The following is a description of a gene set: Increased concentration of 11-deoxycortisol in the circulation. 11-deoxycorticosterone, which is also known as simply deoxycorticosterone and 21-hydroxyprogesterone, is a steroid hormore that is produces in the adrenals and is a precursor to aldosterone. studied in species Homo sapiens Human Gene Set: HP_ELEVATED_SERUM_11_DEOXYCORTISOL Elevated serum 11-deoxycortisol, and this is the list of marker genes: CDKN2A, TP53, CTNNB1 (catenin beta 1), TERT, CYP11B1, CYP11B2, PRKAR1A, POR, ZNRF3